The following is a description of a gene set: Human Gene Set: GOBP_REGULATION_OF_REMOVAL_OF_SUPEROXIDE_RADICALS species: Homo sapiens Any process that modulates the frequency, rate or extent of removal of superoxide radicals., and this is the list of marker genes: DHFR, CD36, NFE2L2, FBLN5, DHFRP1, BMP7, GCH1